Given this list of marker genes NFKB2, BGN, PTGDS, KAT7, PPP1R8, PCBP1, ADIRF (adipogenesis regulatory factor), DRAM2, LARP1B, AGO2, RPL41, TP53, DDX21, NCKAP1, here is a description of the gene set: Cluster 7: genes up-regulated in SW260 cells (colon cancer) by curcumin and sulindac. Human Gene Set: MARIADASON_RESPONSE_TO_CURCUMIN_SULINDAC_7 The short-chain fatty acid butyrate, produced by microbial fermentation of dietary fiber in the large intestine, is a physiological regulator of major pathways of colonic epithelial cell maturation: cell cycle arrest, lineage-specific differentiation, and apoptosis. Microarray analysis of 8,063 sequences demonstrated a complex cascade of reprogramming of SW620 colonic epithelial cells upon treatment with butyrate characterized by the progressive recruitment of gene sets as a function of time. Comparison with the effects of trichostatin A, in conjunction with differences in the kinetics of alteration of histone acetylation induced by butyrate and trichostatin A, identified subsets of induced and repressed genes likely coordinately regulated by altered histone acetylation. The butyrate response was also compared in detail with that of sulindac, a nonsteroidal anti-inflammatory drug with significant chemopreventive activity for colon cancer, and curcumin, a component of mustard and curry structurally and functionally related to sulindac that also has chemopreventive activity. Although gene clusters were identified that showed similar responses to butyrate and sulindac, the data were characterized by the extensive differences in the effects of the two agents. This was striking for functional classes of genes involved in signaling pathways and in cell cycle progression, although butyrate and sulindac induce a similar G0-G1 arrest, elevation of beta-catenin-Tcf signaling, and apoptotic cascade. As regards cell cycle arrest, the underlying mechanism in response to butyrate was most similar to that of the Caco-2 cell line that had spontaneously undergone a G0-G1 arrest and least similar to the G2-M arrest stimulated by curcumin. Thus, high-throughput microarray analysis of gene expression profiles can be used to characterize and distinguish the mechanisms of response of colonic epithelial cells to physiological and pharmacological inducers of cell maturation. This has important implications for characterization of chemopreventive agents and recognition of potential toxicity and synergies. The data bases, gene clusters, and analyses are available at http:// sequence.aecom.yu.edu/genome/. from publication Mariadason JM, Corner GA, Augenlicht LH (PMID 10969808) species: Homo sapiens